Given this list of marker genes HEG1, RPL30, SUPT4H1, SIK1, LPAR2, PLA2G4C, SORBS3, EIF3A, MAGED2 (NCBI Gene Id 10916), THBD, ADD3, RPL37, PLCD1, TNFAIP3, PPP6R2, ATXN7L3B, PYGM, KDM2A, SETD1B, PTH2R, IKBKG, GIPC1, TERF1, UBXN1 (NCBI Gene Id 92151), PFDN5, TENM1, RRP8, BTG1, FHIT, ZFP36L2, UBE2B, CD59, PADI2, FASN, STMN2, POU6F1, AUTS2, ARID4B, PLA2G1B, FOXO4, TLR1, DDX28, GADD45A, ZBTB1, BID, LTB, RCE1, CCR7, PDE4B, SORL1, RPL32 (ribosomal protein L32), EPHB6, TRIB2 (NCBI Gene Id 28951), RFX5, RPL22, ILRUN, CTSW, DGKA, MNT, ST3GAL6, CD48, AREG, YWHAZ, TXNIP, TPM2, MATR3, DDX5, TUBB2A, CDC42BPA, ENC1, RPL29, RPS8, POLR3F, IL11RA, SPP2, CDC14A (NCBI Gene Id 8556), SEPTIN9, NCOA1, VAMP2, JUNB, SGSM2, BCL11A, SERPINF1, AKAP17A (NCBI Gene Id 8280), VIPR1, CHKA, PRKACG, RPL10, ITGA2B, OPRK1, RAPGEF2, HBP1, KCNA5, FCMR (NCBI Gene Id 9214), RPS14, RPS15A, RPL11, B3GALT4, HOXA5, MAL, PIK3IP1, TOE1, CXCR4, CADPS, TSC22D2, ATG13, NUCB2, EXTL3, UBA7, IL7R, PPEF2, RPLP2 (NCBI Gene Id 6181), LITAF, KAT7, FCHSD2, RBL2, FTH1, TDRD3, EYA2, TSN, LRPAP1, MOAP1, SNAP91, BTN3A1, CIRBP, ZNF8, TUBA1A, LHFPL2 (NCBI Gene Id 285713), TIPARP, GABARAPL1, BTG2, CLK1, RASA3, DUSP8, RPS13, USP6NL, KDELR3, RANBP2, LEPROTL1, MAD1L1, IFFO1, PRDM1, RPL31, MYCNOS, USP34, ITPKB, TPP1, ARHGEF18, RPL34, CYBB, HLA-E, SUN2, MFGE8, LGALS3BP, AKAP8, STK17A, JOSD1, CD247, SRSF6, RPS12, HHEX, SARAF, RGS1, ARL4C, RBM38, CENPB, MFSD5, NSFL1C, TRIM2, PNISR, DDIT3, ARHGAP45, PLIN1, CTSK, GYPB, SRCAP, CTSO, SYNE2, CYTH1, DSC3, EIF4A2, HAS2, PCMTD2, IFITM1 (interferon induced transmembrane protein 1), CLSTN1, DLG5 (discs large MAGUK scaffold protein 5), VPS9D1, JUND, TOB1, ITIH4, PER1, CYP3A5, HLA-J, USP15, LAPTM5, PRDM2, RBM6, EIF1, MCC, here is a description of the gene set: Genes up-regulated in follicular helper T cells: BCL6 high versus BCL6 low. Human Gene Set: GSE24574_BCL6_HIGH_VS_LOW_TFH_CD4_TCELL_UP studied in species Homo sapiens We found that a number of Tfh cells downmodulated BCL6 protein after their development, and we sought to compare the gene expression between BCL6-hi Tfh cells and BCL6-low Tfh cells. from publication Kitano M, Moriyama S, Ando Y, Hikida M, Mori Y, Kurosaki T, Okada T (PMID 21636294)